The following is a description of a gene set: from publication Nakaya HI, Wrammert J, Lee EK, Racioppi L, Marie-Kunze S, Haining WN, Means AR, Kasturi SP, Khan N, Li GM, McCausland M, Kanchan V, Kokko KE, Li S, Elbein R, Mehta AK, Aderem A, Subbarao K, Ahmed R, Pulendran B (PMID 21743478) Genes up-regulated in comparison of myeloid dendritic cells from LAIV influenza vaccinee at day 7 post-vaccination vesus those from TIV influenza vaccinee at day 7. Human Gene Set: GSE29618_LAIV_VS_TIV_FLU_VACCINE_DAY7_MDC_UP species: Homo sapiens Systems vaccinology has emerged as an interdisciplinary field that combines systems wide measurements and network and predictive modeling applied to vaccinology. Here we used the systems vaccinology approach to study the molecular mechanisms underlying th, and this is the list of marker genes: STK17B, PRKCA, TUBD1, ZNF480, PPM1G, TFAP4, STX10, TEX261, NEU3, TMOD3, PRMT3, NAT8B, KLF9, RFWD3, SRR, SMARCB1, CASS4, ZNF614, KCNE5, ZNF93, UNC13B, LSM14B, CLCA4, PTGS2, RGS1, LYPLA1, UNC5C, CZIB, MDFIC, RAB8B, CD48, OR2H1, NSD1, CHEK2, AP2S1, SPTLC2, OSMR, COLEC10, AMMECR1, UBXN6, H3C7, NDNF, RASA1, XYLB, ANKRD17 (ankyrin repeat domain 17), FOSB, PIK3R1, ZNF33B, ENTPD4, APOC2, ZSCAN9, ZNF107, COL8A1, H1-1, STK38L, CCSER2, CAPN15, ST7L, SETMAR, CRK, PRKAG1, LAMB4, MIPEP, MEIS2, PDSS1, SPATS2L, RASSF4, CSTF3, SLC25A1, RARA (NCBI Gene Id 5914), ZNF200, U2AF2, HFE, GORASP1, SLC38A1, GABRG2, MCOLN1, MROH7, GALNT1 (NCBI Gene Id 2589), LILRA6, COL6A2, SYBU, MORC3, CNOT7, ADRB1, PLEKHA2, CDC42, CSDE1, MYH9, YY1, SCCPDH, TEX13B, VWA8, MYL3, PLOD2, GNGT1, RASA2, SEMA4D, SNAI1, AIDA, MYO7A (NCBI Gene Id 4647), IDI2-AS1, PCDH17, TNPO1, EXOC1, VDAC2 (voltage dependent anion channel 2), NR4A2, WNT2, SSX1, LIMD1, NOP14, HIC2, FBXL14, TPTE, SF3A2, GPR37L1 (NCBI Gene Id 9283), C2CD3, STAG1, NEK9, NPAT, CEP131, PCDHGA10, HES1, SLC10A3, RNF38, PSMC3, ARHGAP32, ZNF451, IMPG2, CLK1, PAK2, XPO7, ZSCAN16, CD34, PUM1, PHTF1 (NCBI Gene Id 10745), DIO3, DUS1L, PGM1, INCENP, DAB2, IFNAR1, NUBPL, TMEM176B, JPH2, TRIM68, TLN1, USP16, RPS2, ZMAT3, MAPKAPK2, LZTFL1, P2RY10, IKZF1 (NCBI Gene Id 55429), MSRB1, HIGD1B, ASIC2, IL4R (NCBI Gene Id 3566), PHACTR4, PSG2, ORC3, MED13L, CTSC (cathepsin C), FXR1, DAZL, AHCYL1, FYCO1, LLGL2 (LLGL scribble cell polarity complex component 2), IGHV5-78, ACTR5, LILRA1, RNASE6, HDAC9, DKK3 (dickkopf WNT signaling pathway inhibitor 3), PTER, PRRC2B, CHMP1B, TSPAN12, SMIM27, SORT1, SLC4A8, CUL2, FBXL8, JUNB, NAALAD2, SIRT3, GNG11, NONO, MTUS2, TMEM187, SUOX, NR4A3, VGLL3 (NCBI Gene Id 51159), LRRC59, PRKX, IKZF2, TEF